Given this list of marker genes GATA4, ACVR2B, NOTCH1, SHH, FOXF1, CTNNB1, NCKAP1, EPB41L5, SOX17, SMAD2, SMAD3, here is a description of the gene set: Human Gene Set: GOBP_FOREGUT_MORPHOGENESIS studied in species Homo sapiens The process in which the anatomical structures of the foregut are generated and organized.